The following is a description of a gene set: ROBO1 receptor, activated by SLIT2, binds to MYO9B and inhibits its RHOA GAP activity. SLIT2-ROBO1 signaling thus results in increased RHOA activity, which is thought to negatively regulate invasiveness of lung cancer cells. ROCK-mediated signaling and phosphorylation of the myosin regulatory light chain (MLRC) downstream of activated RHOA is needed for SLIT-mediated axon pathfinding in cranial motor neurons. studied in species Homo sapiens part of: Signaling by ROBO receptors Reactome Pathway: SLIT2:ROBO1 increases RHOA activity, and this is the list of marker genes: MYO9B, RHOA, SLIT2, ROBO1